Given this list of marker genes P2rx7, Gria1, Ifna1, Dhx9, Ifih1, Flot1, Npm1, Ifnz, Ddx21, Rftn1, Ifna5, Irf3, Ripk2, Riok3, Gm13271, Ifna15, Zcchc3, Ifne, Ifna9, Peli1, Ifna16, Tlr3, Cgas, Ddx1, Kcnj8, Mul1, Mapk1, Nod2, Zc3hav1, Gm13276, Gm13283, Ifna11, Irak3, Gm13277, Ifna4, Ifna12, Ifna7, Rigi, Nfkb1, Ralb, Ifnk, Ifnb1, Ifna6, Colec12, Pmaip1, Ticam1, Ifnab, Ifna14, Sting1, Dhx36, Ifna13 (NCBI Gene Id 230396), Nfkbia, Ifna2, Stat1, Gm13275, Ciita (NCBI Gene Id 669998), Raet1d (retinoic acid early transcript delta), Pde12, Pqbp1, Cav1, Hcfc2, Card9, Gm13272, Rftn2, Mapk3, Slc3a2, Mavs, here is a description of the gene set: Mouse Gene Set: GOBP_RESPONSE_TO_DSRNA Any process that results in a change in state or activity of a cell or an organism (in terms of movement, secretion, enzyme production, gene expression, etc.) as a result of a double-stranded RNA stimulus. species: Mus musculus